Given this list of marker genes Dnm2, Cltb, Gja1, Ap2m1, here is a description of the gene set: Reactome Pathway: Gap junction degradation studied in species Mus musculus part of: Gap junction trafficking This event has been computationally inferred from an event that has been demonstrated in another species.<p>The inference is based on the homology mapping from PANTHER. Briefly, reactions for which all involved PhysicalEntities (in input, output and catalyst) have a mapped orthologue/paralogue (for complexes at least 75% of components must have a mapping) are inferred to the other species. electronically inferred by orthology from the curated human pathway